Given this list of marker genes RACK1, TNFRSF1A, TNF, SMPD2 (NCBI Gene Id 6610), SMPD3, NSMAF, here is a description of the gene set: part of: TNF signaling TNF-alpha activates sphingomyelinase (SMASE) proteins to catalyze hydrolysis of sphingomyeline into ceramide. Two types of SMASE can be distinguished downstream of TNFR1 signaling, acid and neutral SMASEs (Adam-Klages S et al. 1996, 1998). Neutral SMASE (such as SMPD2,3) has a pH optimum of 7.4, requires Mg2+ ions and is found at the plasma membrane (Rao BG and Spence MW 1976). Acid SMASE is active at pH 4-5, is Zn2+-dependent and is mainly localized in the lysosomes. The death domain of TNFR1 that is responsible for the initiation of the apoptotic pathway also mediates activation of an acid SMASE. The two proapoptotic adaptor proteins TRADD and FADD are also involved in the activation of acid SMASE signaling events (Schwandner R et al. 1998). TNF-alpha can also activate the pro-apoptotic acidic SMASE via caspase-8 mediated activation of caspase-7 which in turn proteolytically cleaves and activates the 72kDa pro-acid SMASE form (Edelmann B et al. 2011). Neutral SMASE(SMPD) binds to adaptor protein NSMAF (FAN), which bridges it to NSMASE-activating domain (NSD) of TNFR1 (Adam D et al. 1996; Adam-Klages S et al. 1996; Ségui B et al. 2001). Activation of SMPD2,3 leads to an accumulation of ceramide at the cell surface.<p>Ceramide metabolism generates a cascade of bioactive lipids, all of which carry a specific signaling capacity. Ceramide can be converted by ceramidase into sphingosine, which in turn is phosphorylated by sphingosine kinase into sphingosine-1-phosphate (S1P). These lipids exert opposite biological effects: ceramide and sphingosine are able to induce anti-proliferative and pro-apoptotic responses, whereas S1P is a cytoprotective molecule that promotes cell growth and counteracts apoptotic stimuli (Cuvillier O et al.1996) Reactome Pathway: TNFR1-mediated ceramide production studied in species Homo sapiens